The following is a description of a gene set: Mouse Gene Set: GOBP_CYTOSOLIC_CILIOGENESIS The process in which an axoneme is exposed entirely or partially to the cytoplasm or by which the cytoplasmic portion is assembled or extended. Cytosolic ciliogenesis can occur following compartmentalized ciliogenesis, in which the cilium is formed within a compartment separated from the cytoplasm. species: Mus musculus, and this is the list of marker genes: Rab34, Wdr44, Usp9x, Iqcb1, 4933427D14Rik